The following is a description of a gene set: Esophageal varix Human Gene Set: HP_ESOPHAGEAL_VARIX Extreme dilation of the submucusoal veins in the lower portion of the esophagus. species: Homo sapiens, and this is the list of marker genes: ALMS1, POU2AF1, IL12RB1 (interleukin 12 receptor subunit beta 1), CBS, ACVRL1, DCDC2, SPIB, F5, SMAD4, SLC30A10, PHKG2, RBPJ, DLL4, GBE1, ARHGAP31, GNB2, CALR, KRT18, JAK2, IFT56, DOCK6, KIF3B, EOGT, IL12A, TNFSF15, FARSB, ENG, STN1, DZIP1L, MED12, DGUOK, GDF2, TNPO3, COG6, TMEM67, ATP7B, KIF12, MMEL1, POT1 (NCBI Gene Id 25913), GIMAP5, NOTCH1, IRF5, ADA2, GBA1, PHKA2, PKHD1, LIPA